Given this list of marker genes LSM11, TXK, PDE6H, MBNL3, ATP2B3, DAPK1, RAB27B, DDX59, ANTXR1, ADGRG6, PRKAG1, NR3C1, BRD1, DCUN1D4, KCNA4, MAEL, BIRC3 (baculoviral IAP repeat containing 3), NEDD4L, LMAN1, RNF144B, GPBP1L1, FGF14, SCGB1D2, MAPK9, CCDC141 (NCBI Gene Id 375296), C4orf19, HPGD, SYN3, GC, CPED1, KCNJ1, MCPH1, ARL8A, RDH11, RBM43, PIK3C2B, NECTIN3, TNFSF14, SLC17A8, ZNF22, ADD1, CDC7, NCL, LONRF3, SERPINH1, ERBIN, here is a description of the gene set: from publication Chen Y, Wang X (PMID 31504780) Genes predicted to be targets of miRBase v22 microRNA hsa-miR-616-3p in miRDB v6.0 with MirTarget v4 prediction scores > 80 (high confidence targets). Human Gene Set: MIR616_3P studied in species Homo sapiens